The following is a description of a gene set: Mouse Gene Set: CUI_MIGDC_IL10_RESPONSE_DN Genes negatively differentially expressed in cell type: MigDC (migratory dendritic cell) upon treatment with cytokine: IL-10 in mouse lymph nodes in vivo. from publication Cui A, Huang T, Li S, Ma A, Pérez JL, Sander C, Keskin DB, Wu CJ, Fraenkel E, Hacohen N (PMID 38057668) Cytokines mediate cell-cell communication in the immune system and represent important therapeutic targets. A myriad of studies have highlighted their central role in immune function, yet we lack a global view of the cellular responses of each immune cell type to each cytokine. To address this gap, the authors created the Immune Dictionary, a compendium of single-cell transcriptomic profiles of more than 17 immune cell types in response to each of 86 cytokines (>1,400 cytokine-cell type combinations) in mouse lymph nodes in vivo. A cytokine-centric view of the dictionary revealed that most cytokines induce highly cell-type-specific responses. For example, the inflammatory cytokine interleukin-1β induces distinct gene programmes in almost every cell type. A cell-type-centric view of the dictionary identified more than 66 cytokine-driven cellular polarization states across immune cell types, including previously uncharacterized states such as an interleukin-18-induced polyfunctional natural killer cell state. studied in species Mus musculus, and this is the list of marker genes: Pbx1, Dusp1, Fos, Anxa3, Vwa5a, Mt1, Rgs1, Ccr7, Hspa1a, Tmem19 (transmembrane protein 19), Fam53b, Amn1, Fosb, Dock10, H2-M2, Ubc, Mfge8, Btg2, Mxd1, Plaat3, Fuca1, Epsti1, Slc44a1 (NCBI Gene Id 73760), Synpo2, Vps13a, Rcsd1, Il15, Klf2, H2-Q6, Mbp